The following is a description of a gene set: Mouse Gene Set: REACTOME_SIGNALING_BY_LTK studied in species Mus musculus Signaling by LTK, and this is the list of marker genes: Tnk2, Shc1, Pik3r2, Alkal1, Grb2, Sos1, Alkal2, Pik3cb, Pik3ca, Ltk, Pik3r1